The following is a description of a gene set: studied in species Homo sapiens Abnormal gastrointestinal vascular morphology Human Gene Set: HP_ABNORMAL_GASTROINTESTINAL_VASCULAR_MORPHOLOGY, and this is the list of marker genes: GDF2 (growth differentiation factor 2), CTC1, ENG, VWF, GLMN, SMAD4, ACVRL1